Given this list of marker genes TBL1Y (transducin beta like 1 Y-linked), PSMA6, FMR1NB, PDCL (phosducin like), TUBGCP2, PSMA7, SIPA1L2, PSMB1, ITIH5, ZMIZ1, PSMC3, NDOR1, FGD4, ACRBP, PSMA8, MPP7, PSMD1, RNF151, STARD6, B3GNT9, ARHGAP42, FSIP1, PSMD3, FBH1, DNAH10, ADGRD2, PAPLN, POGLUT3, DNHD1, LRFN5, TUBA8, GAL3ST4, SYT13, HS6ST2, IGSF21, RAB9A, NTNG2, C1QTNF3, here is a description of the gene set: species: Homo sapiens Abundant evidence suggests that a unifying principle governing the molecular pathology of cancer is the co-dependent aberrant regulation of core machinery driving proliferation and suppressing apoptosis. Anomalous proteins engaged in support of this tumorigenic regulatory environment most probably represent optimal intervention targets in a heterogeneous population of cancer cells. The advent of RNA-mediated interference (RNAi)-based functional genomics provides the opportunity to derive unbiased comprehensive collections of validated gene targets supporting critical biological systems outside the framework of preconceived notions of mechanistic relationships. We have combined a high-throughput cell-based one-well/one-gene screening platform with a genome-wide synthetic library of chemically synthesized small interfering RNAs for systematic interrogation of the molecular underpinnings of cancer cell chemoresponsiveness. NCI-H1155, a human non-small-cell lung cancer line, was employed in a paclitaxel-dependent synthetic lethal screen designed to identify gene targets that specifically reduce cell viability in the presence of otherwise sublethal concentrations of paclitaxel. Using a stringent objective statistical algorithm to reduce false discovery rates below 5%, we isolated a panel of genes that represent major focal points of the autonomous response of cancer cells to the abrogation of microtubule dynamics. Here we show that several of these targets sensitize lung cancer cells to paclitaxel concentrations 1,000-fold lower than otherwise required for a significant response, and we identify mechanistic relationships between cancer-associated aberrant gene expression programmes and the basic cellular machinery required for robust mitotic progression. Human Gene Set: WHITEHURST_PACLITAXEL_SENSITIVITY Genes that reduced viability of NCI-H1155 cells (non-small-cell lung cancer, NSCLC) in the presence of otherwise sublethal concentrations of paclitaxel, based on RNAi synthetic lethal screen. from publication Whitehurst AW, Bodemann BO, Cardenas J, Ferguson D, Girard L, Peyton M, Minna JD, Michnoff C, Hao W, Roth MG, Xie XJ, White MA (PMID 17429401)